Given this list of marker genes CALM3, CASQ2, RYR2, NOS1AP, PKP2, SLC12A3, MT-ND4, KCNE2, SCN1B, KCNE1, MT-TH, MT-TS2, GYG1, CDH23, SCNN1A, POLG2, DHCR7, SLC25A4, PIGA, SLC4A3, MYH7, HCN4, SCN4B, SYNE2, PRKAG2, NAA10, GPD1L, DOHH, TNNI3, MYL3, KCND3, MYZAP, SYNE1, KCNJ18, MT-ND1, MT-ND2, LMNA, TOR1AIP1, EMD, PLN, TMEM43, MT-CO1, KCNJ2, ALG10B, SCN5A, MT-TF, ABCC9, GJA5, FHL1, CALM2, NDUFS2, TANGO2, MYL2, MT-TV, RRM2B, LAMP2, MT-CO3, MT-ND4L, SCN3B, POLG, GNB5, VEZF1, NDUFB11, IFNG, MRPS14, TNNI3K, BMP2, KCNE3, CACNA1C, CDH2, NDUFAF1, ACTB, KCNJ8, PPP1R13L, MT-TC, TRDN, ATP1A3, KCNQ1, DSG2, GAA, DTNA, SCN10A, BAG5, MT-TL1, SLC25A20, ANK2, MYBPC3, TNNC1, TWNK, CALM1, SEMA3A, TECRL, MT-TQ, DSP, DEPDC5, MT-ND5, TSC1, NFIX, DPP6, ACADVL, RAF1, CLCNKB, LDB3, GABRA3, SLMAP, FNIP1, NPPA, RYR1, TRPM4, TGFB3, CACNA2D1, MT-TW, MT-CO2, JAG2, CAV3, SGO1, TBX5, MT-TK, CACNB2, CACNA1S, TCAP, SCN2B (sodium voltage-gated channel beta subunit 2), RANGRF, MT-ATP6, SNTA1, KCNJ5, AKAP9, CNBP, MT-ND6, MT-CYB, TSC2, KCNH2, MTFMT, DSC2, GTPBP3, ACTC1, DNAJC30, KCNE5, JUP, here is a description of the gene set: Human Gene Set: HP_VENTRICULAR_ARRHYTHMIA Ventricular arrhythmia studied in species Homo sapiens